The following is a description of a gene set: Abnormality of the umbilical cord studied in species Homo sapiens An abnormality of the umbilical cord, which is the cord connecting the developing embryo or fetus to the placenta. Human Gene Set: HP_ABNORMALITY_OF_THE_UMBILICAL_CORD, and this is the list of marker genes: FANCF, WASHC5, THSD1, PIGW, ARPC5, F13A1, SCARF2, FOXF1, CLPB, FCGR3B, MYH7, TWIST2, CAPRIN1, RBCK1, SLC30A9, CCDC22 (NCBI Gene Id 28952), LMNA, POR, GNB2, F7, G6PC3, MTHFS, PIGO, SMARCD2, PIGV, TAPT1, GATA6, STAG1 (NCBI Gene Id 10274), SERPINE1, MUSK, FANCB, IL6ST, ZMPSTE24, HSPG2, F13B, PGAP2, MYD88, PACS1, PHGDH, WNT3, DPF2 (NCBI Gene Id 5977), HNRNPK, MCTP2, ZNF699, SPECC1L (NCBI Gene Id 8221), ADGRG6, PAK2, PGAP3, HPS6, HOXD13, PIGL, MAX, RAC2, WT1, TRAF7, VPS35L, CACNA1C, MKS1, DPYSL5, TLK2, ITGB2, NRAS (NCBI Gene Id 4893), RNF31, FAT4, QRICH1, PIGY, DDX6, C1QC